The following is a description of a gene set: Human Gene Set: GOCC_OXIDOREDUCTASE_COMPLEX Any protein complex that possesses oxidoreductase activity. species: Homo sapiens, and this is the list of marker genes: HSD17B8, SDHB, PDK2, CAT, BCKDHB, HADHA, GLDC, NDUFV3, NDUFV1, RAC3, NDUFS4, DLST, NOX5, NDUFA2, NDUFA8, PDHB, AMT, MT-CO3, RRM2, DUOX1, NDUFB7, UQCRQ, MT-ND3, LDHAL6B, COX7B, DHTKD1, GCSH, NCF1B, DBT, P4HB, NCF4, UQCR10, NCF1, PDHX, NDUFA3, OGDH, MT-ND4 (NCBI Gene Id 4538), COX5A, NDUFS8, COX4I2, NDUFAB1, NDUFB1, NDUFB10, NDUFB11, MT-CO2, NDUFB5, COX6C, CYC1, NOX4, COX6A2, METTL3, DUOX2, MT-CYB, NDUFV2, P4HA1, DLD (NCBI Gene Id 2654), UQCRC2, CBR4, NDUFB8, COX6B2, ABHD11, MT-ND2, BCS1L, NDUFB9, MT-ND5, COX8C, NOX1, CYBA, RRM2B, HADHB, NOXA1, COX7A2, UQCRC1, MT-ND6, NDUFB3, CYB5B, NDUFA6, NDUFC2-KCTD14, IDH3B, COX6B1, METTL4, NDUFAF2 (NCBI Gene Id 91942), KGD4, PDHA2, SDHC, COX7A2L, COX6A1, UQCRH, RAC1, UQCR11, IDH3G, COX4I1, NDUFA12, NDUFB4, GMPR (NCBI Gene Id 2766), NOX3, NDUFC1, NDUFS7, NDUFS6, LDHA, LDHC, NDUFA4L2, COX7A1, NDUFS5, NDUFS2, NCF1C, BCKDK, PDK1, RRM1, NDUFA13, NOXO1, IDH3A, UQCRHL, COX8A (cytochrome c oxidase subunit 8A), NDUFA7, LDHB, COX7B2, NDUFA10, MT-ND4L, NDUFB2, UQCRB, COX7A2P2, MTARC1, COX7C, CYB5R3, NDUFC2, NDUFA5, CYBB, NCF2, OGDHL, NDUFB6, NDUFA9 (NCBI Gene Id 4721), MT-ND1, WDR93, UQCRFS1P1 (ubiquinol-cytochrome c reductase, Rieske iron-sulfur polypeptide 1 pseudogene 1), BCKDHA, UQCRFS1, NDUFS3, NDUFA1, NDUFA11, MT-CO1, GMPR2, ACACB, NDUFA4, C15orf48, RAC2, SDHA, KAT2A, MTCO2P12, DLAT, PDHA1, COX5B, NDUFS1, SDHD